The following is a description of a gene set: Any process involved in the carrying out of an immune response by a myeloid leukocyte. species: Homo sapiens Human Gene Set: GOBP_MYELOID_LEUKOCYTE_MEDIATED_IMMUNITY, and this is the list of marker genes: F2RL1, RIGI, FOXF1, KIT, TRAF3IP2, HLA-E, VAMP8 (vesicle associated membrane protein 8), RAB44, SPI1, WDR1, CLNK, SCNN1B, VAMP2, FCGR2A, FERRY3, SYK, ELANE, PLA2G3, CCL3 (C-C motif chemokine ligand 3), IRAK4, PRAM1, DHX36, DAO, KMT2E, FCGR3A, FCAR, BCR, JAGN1, VAMP3, POMC, IL13RA2, NDST2, SNX6, FES, GAB2, STXBP3, BTK, RASGRP1, SERPINB9, DNASE1L3, CD300A, RAC2, S100A13, IL4R, FGR, STX4, IGHG1, MAVS, LGALS9, FCER1G, ARG1 (arginase 1), DDX1, GPR15LG, SLC18A2, MILR1, CD177, SNAP23, FCER1A, MRGPRX2, UNC13D, IGHE, GATA1 (GATA binding protein 1), NLRP6, C3, CTSG, CARD9, FCGR1BP, SPHK2, FCGR3B, SNX4, CBL (Cbl proto-oncogene), DNASE1, LYN, ITGB2, PTGDR, MYD88, TREM1, SPON2, CD84, LAT, PTGDS, PDPK1, ACE, CX3CR1, STXBP2, F2, NCF1, GRP, FCGR2B, AZU1, ADGRE2, TICAM1, FCGR1A, PCYOX1L, GATA2, STXBP1, NR4A3, CCR2, STAP1, ITGAM, ADORA2B, DDX21, TYROBP, IL6R, LAT2, TUSC2, PIK3CG, FCGR2C, RABGEF1, ANXA3, IL13, PLA2G1B, PIK3CD, ADAM17, VAMP7, CAMK4, CXCL6 (NCBI Gene Id 6372), CPLX2, SCN11A, IL6, CHGA